Given this list of marker genes Krtap10-26, Crmp1, Arhgap35, St8sia4, Krt73, Krt32, Ptpra, Krt80, Krt2, Krtap2-20, Col2a1, Krtap9-21, Tcf7l1, Hint1, Krt17, Krtap31-2, Krt26, Krtap4-26, Grb2, Krt36, Cdk4, Pik3ca, Krtap4-13, Efna5, Ephb2, Sema5a, Pfn1, Krt82, Sirt1, Rhoc (ras homolog family member C), Psenen, Spta1, Krtap6-3, Gm4553, Map2k2, Dsg3, Dsc2, Akt2, Efna4, Krtap10-33, Gdnf, Dsp, Krt35, Lef1 (NCBI Gene Id 99641), Krtap5-24, Clta, Eef1e1, Itgav, Lars1, Krtap19-5, Ephb1, Tubal3, Mitf, Lipk, Stfa2l1, Dars1, Akt1, Dok5, Plxna4, Krtap11-1, Plxnd1, Limk1, Col4a4, Csf1, Vav3, Krtap20-20, Gm5414, Krtap12-22, Rasa1, Tubb4b, Col9a3, Pik3r2, Ptprc, Ntn4, Col4a5, Vldlr, Kazn, Col4a2, Col9a2, Arhgef7, Sin3a, Pip5k1c, Krtap9-5, Krt25, Krtap5-1, Krtap4-6, Krt12, Ephb3, Krt13, Krtap10-32, Krtap4-22, Dok2, Foxo1, Col6a5 (collagen, type VI, alpha 5), Krtap10-25, Irs2, Yes1, Numb, Actr3, Tuba4a, Tln1, Krt71, Sh3kbp1, Pkp3, Epha1, Rara, Lgi4, Krt6b, Ephb4, Usf1, Dsc1, Sptbn5, Nck2, Krtap20-2, Actb, Ncor2, Krt76, Sema7a, Cela2a, Epha7, Krtap6-5, Sdcbp, Tubb2b, Ranbp9, Krtap2-22, Tgm1, Krt9, Dscam, Sos1, Myf5, Nck1, Krt34, Tubb3, Gfra3, Cdc42, Efna1, Fgfr1, Krtap10-21, Frs2, Krtap10-29, Rras, Epha8, Dlg4, Cdon, Actr2, Krtap10-30, Tuba1b, Krtap20-21, Arhgef11, Klk14, Krt18, Col6a2, Dock1, Sema6d, Gab1, Tcf12, Ank1, Dok4, Plxna2, Krtap4-2, Kras, Krtap3-3, Ep300, Hdac1, Tubb2a, Nrtn, Met, Egfr, Ubb, Krtap19-4, Krtap20-1, Krt1, Itgb1, Pik3cb, Col5a3, Krt14, Dpysl4, Mapk1, Efna2, Spink6, Pfn2, Tfap2b, Tuba1a, Krtap2-21, Grin1, Kit, Krt72, Krt7, Aimp1, Mef2b, Akt3 (thymoma viral proto-oncogene 3), Gm36368, Krtap6-6, Myo9b, Krtap4-23, Mapk11, Lipm, Slit3, Dsg2, Krt5, Gm5478, Enah, Tyrobp, Ppl, Tcf7, Rock2, Klk8, Tfap2a, Cdh15, Krt33a, Itga2b, Gsk3b, Epha10, Kalrn, Creb1, Actg1, Krtap9-22, Grb10, Krtap5-26, Lgi2, Aimp2, Krt81, Mmp2, Plcg1, Krtap4-25, Iars1, Krtap20-24 (keratin associated protein 20-24), Krt79, Spink5, Unc5a, Krtap19-1, Mark3, Hsp90ab1, Krtap5-4, Efnb3, Sema3e, Dsg1a, Mapk3, Col5a1, Csnk2a1, Cxcr4, Krtap4-20, Smad2 (NCBI Gene Id 319898), Krtap10-23 (NCBI Gene Id 100041281), Evl, Krtap31-1, Rock1, Dab1, Itga5, Aph1b, Adam23, Klk12, Krt6a, Pkp2, Krtap19-3, Cdk5r1, Krtap3-1, Cacng8, Adgrg6, Krt15, Eprs1, Sema4d, Ptpn11, Plxnb1, Krt40, Krt84, Krt77, Krt78, Vav2, Map2k1, Arpc5, Arpc2, Hsp90aa1, Uba52rt, Mapk14, Casp14 (caspase 14), Krtap1-3, Sptan1, Gap43, Ret, Sytl2, Cdkn1a, Krtap19-2, Klk5, Ctnna1, St8sia2, Sdc2, Krtap10-27, Cdh4, Nrp1 (NCBI Gene Id 270112), Arpc4, Krtap1-4, Lipn, Shank3, Krt20, Csnk2b, Prkacb, Pspn, Krtap20-22, Rhoa, Trio, Krtap4-21 (NCBI Gene Id 670472), Rps6ka5, Ube2i, Ngef, Krtap4-16, Dnm1, Sptbn2, Krtap6-1, Adam22, Krt28 (keratin 28), Col6a1, Dpysl3, Pak1, Ncstn, Pik3r1, Myod1, Smad3 (NCBI Gene Id 17127), Myrip, Krt4 (keratin 4), Tcf7l2, Krtap12-20 (keratin associated protein 12-20), Rptn, Plxna1, Lgi3, Tnfsf11, Dpysl5, Gm10153, Mapk12, Krt33b, Krtap2-4, Dsg4, Sptbn4, Farp2, Cxcl12, Rdx, Krtap4-7, Pik3r3, Fyn, Jup, Mmp9, Ctnna2, Mef2c, Krt19, Src, Krtap4-8, Krtap6-7, Krtap13-22, Wnt3a, Cdk2, Efnb1, Tuba1c, Sprr3, Ephb6, Plxnb3, Krtap3-2, Smad4 (NCBI Gene Id 28063), Stx1a, Aph1a, Tchh, Krtap12-1, Lgi1, Krt74, Myf6, Sema4a, Mapk7, Krtap4-1, Tcf4 (transcription factor 4), Krtap13-1, Shc1, Kars1, Cacng3 (calcium channel, voltage-dependent, gamma subunit 3), Krtap5-22, Gfra4, Krt83, Rps6ka1, Nfasc, Arhgef28, Abl1, Artn, Csnk2a2, Krtap10-28, Pak2 (p21 (RAC1) activated kinase 2), Ap2b1, Erbb2, Sptbn1, Krtap10-22, Epha6, Krtap13-20, Tubb4a, Cdh2, Gfra1, Krtap12-21, Tuba8, Krt87, Gfra2, Abl2, Mef2d, Psen1, Arpc1b, Shc3, Krtap9-3, Pik3cd, Krt27 (NCBI Gene Id 16675), Lyn, Krt75, Krtap13-23 (keratin associated protein 13-23), Sptb, Col4a1, Krt16, Pkp1, Krtap5-21, Cltc, Ap2a2, Itsn1, Fes, Dpysl2, Krt8, Grb7, Tuba3b, Cdsn, Ap2s1, Dnm3, Itgb3, Mlph, Evpl, Krtap4-24, Col6a6, Krtap5-25, Rnd1, Rab27a, Lypla2, Krtap13-21, Krt86, Pkp4, Git1 (GIT ArfGAP 1), Kitl, Krtap13, Dag1, Prkcq, Krtap9-20 (NCBI Gene Id 100415785), Prkaca, Rap1gap, Slit2 (slit guidance ligand 2), Rac1, Krtap4-27, Myo5a (myosin VA), Cdk5, Tuba3a, Col6a3, Krtap8-1, Pak3, Reln, Usp33, Stx1b, Efnb2, krtap20-23, Cd72, Krt31, Mars1, Hras, Tubb6, Dsc3, Dscaml1, Foxo3, Cacng2, Arpc3, Ubc, Bnip2, Itga9, Spag9, Krtap9-1 (keratin associated protein 9-1), Klk13 (kallikrein related-peptidase 13), Xpo1, Ctnnb1, Arhgef12, Krtap5-23, Dok1, Gpc1, Tbx3, Rps27a, Col3a1, Krt85, Col4a3, Krtap10-31, Krtap24-1, Epha4, Hdac3, Ptk2, Dcc, Krtap29-1, Col5a2, Krtap1-5, Pdlim7, Krtap10-10, Perp, Cebpa, Krtap31-3, Krtap4-9, Qars1, Rars1, Krtap10-4, Tfap2c, Rhob, Myog, Tubb1, Trem2, Krt24, Dnm2, Efna3, Ap2m1, Krtap10-24 (NCBI Gene Id 100046436), Ap2a1, Stfa2, Krt10, Adam11, Krtap10-34, Sox10, Krtap5-5, Ezr, Krtap5-20, Vasp, Krtap16-3 (keratin associated protein 16-3), Cacng4, Msn, Krt23, Tcf3, Arpc1a, Krt39, Krtap5-2, Sh3gl2, Dok6, Col9a1, Rxra, Plxna3, Sumo1, Uba52, Kif4, Plxnc1, Krtap16-1, Epha2, here is a description of the gene set: Developmental Biology studied in species Mus musculus Mouse Gene Set: REACTOME_DEVELOPMENTAL_BIOLOGY